Given this list of marker genes MIB1, DTX2, PSEN2, ADAM10, ADAM17, RPS27A, DNER, ARRB2, APH1A, UBC, NEURL1B, UBA52, ITCH, NUMB, DLL4, CNTN1 (NCBI Gene Id 1272), DLK1, NEURL1, JAG1 (jagged canonical Notch ligand 1), NOTCH1, NCSTN, DTX1, PSEN1, DTX4, DLL1, UBB, MIB2, APH1B, PSENEN, JAG2, ARRB1, here is a description of the gene set: Mature NOTCH1 heterodimer on the cell surface is activated by one of its ligands: DLL1, DLL4, JAG1 or JAG2, expressed in trans on a neighboring cell. Thus, a ligand-expressing cell is a signal-sending cell, while the NOTCH1 expressing cell is a signal-receiving cell. If NOTCH1 has undergone Fringe modification in the Golgi, it is preferentially activated by Delta ligands, DLL1 and DLL4. <br><br><br>Upon binding to NOTCH1 on a neighboring cell, NOTCH ligands are ubiquitinated by Mindbomb (MIB1 and MIB2) and/or Neuralized (NEURL and NEURL1B) E3 ubiquitin ligases and endocytosed. Endocytosis of ubiquitinated ligands is thought to mechanically stretch the bound NOTCH1 receptor, exposing a cleavage site S2 that is recognized by ADAM10 and/or ADAM17 metalloprotease (van Tetering et al. 2009, Brou et al. 2000, Hartmann et al. 2002, Pan et al. 1997). S2 cleavage of NOTCH1 produces the NEXT1 fragment which is further cleaved at an S3 cleavage site by the gamma-secretase complex, resulting in release of the NOTCH1 intracellular domain (NICD1) into the cytosol (de Strooper et al. 1999, Schroeter et al. 1998, Huppert et al. 2000). NICD1 produced by activation of NOTCH1 in response to in trans presented Delta and Jagged ligands (DLL/JAG) traffics to the nucleus where it acts as a transcription regulator.<br><br><br>NOTCH1 signaling can also be activated by ligands other than DLL1, DLL4, JAG1 and JAG2. CNTN1 (Contactin-1), transiently expressed during central and peripheral nervous system development, activates NOTCH1 and NOTCH2 in trans, promoting oligodendrocyte maturation and myelination. DNER (Delta and Notch-like epidermal growth factor-related receptor) is a transmembrane protein specifically expressed in dendrites and cell bodies of postmitotic neurons. Activation of NOTCH1 by DNER in trans may play an important role in development of the central nervous system by influencing differentiation of astrocytes. Activation of NOTCH1 by both CNTN1 and DNER is Deltex (DTX)-dependent and results in gamma-secretase mediated release of NICD1. Three members of the Deltex protein family: DTX1, DTX2 and DTX4 possess a domain involved in binding cdc10/ankyrin repeats of NOTCH. DTX proteins are considered as positive regulators of NOTCH signaling, although the exact mechanism has not been elucidated.In addition, DTX can mediate downregulation of NOTCH signaling by recruiting non-visual beta-arrestins to NOTCH, thereby trigerring NOTCH ubiquitination. DTX proteins are negatively regulated by ITCH (AIP4) ubiquitin ligase.<br><br>NOTCH1 signaling in the signal-receiving cell can be turned off in cis by expression of NOTCH ligands DLL/JAG, as well as DLK1. Formation of NOTCH1:ligand complexes in cis prevents interaction of NOTCH1 with ligands expressed in trans, resulting in the inhibition of NOTCH signaling. In the signal-sending cell, NOTCH signaling can be negatively regulated by the protein NUMB, which is asymmetrically distributed during cell division. NUMB recruits ITCH ubiquitin ligase to NOTCH1 and promotes sorting of NOTCH1 through late endosomes for degradation. part of: Signaling by NOTCH1 species: Homo sapiens Reactome Pathway: Activated NOTCH1 Transmits Signal to the Nucleus